Given this list of marker genes RPL29, RPL9, BAMBI, ABHD3, TAF1D, XPO7, SCARB2, OXT, RPL23A, RPS10, GNAS, GNPAT, RPS4Y1, SPTBN1, AHCY, MDK, EPCAM, RPS7, RPL28, HNRNPA1 (heterogeneous nuclear ribonucleoprotein A1), SRPK1, TOMM20, RPS4X, PEG3, RPL13A, RPS3, RPL31, VIL1, RPSA, MPZL2, RPL7A, FMOD, RPS12, PHF20, DSG2, POLR2E, AFP, RPS27A (NCBI Gene Id 6233), TRIM24, CPOX (coproporphyrinogen oxidase), TTK, RPLP0, XK, RPL17, EIF3F, MRPL3, RPS24, RPS3A, RPL6, DKK1, NREP, RPL35 (ribosomal protein L35), PTPN12, here is a description of the gene set: species: Homo sapiens Up-regulated genes distinguishing hepatocellular carcinoma (HCC) samples positive for EPCAM from the negative ones. Human Gene Set: YAMASHITA_LIVER_CANCER_WITH_EPCAM_UP The heterogeneous nature of hepatocellular carcinoma (HCC) and the lack of appropriate biomarkers have hampered patient prognosis and treatment stratification. Recently, we have identified that a hepatic stem cell marker, epithelial cell adhesion molecule (EpCAM), may serve as an early biomarker of HCC because its expression is highly elevated in premalignant hepatic tissues and in a subset of HCC. In this study, we aimed to identify novel HCC subtypes that resemble certain stages of liver lineages by searching for EpCAM-coexpressed genes. A unique signature of EpCAM-positive HCCs was identified by cDNA microarray analysis of 40 HCC cases and validated by oligonucleotide microarray analysis of 238 independent HCC cases, which was further confirmed by immunohistochemical analysis of an additional 101 HCC cases. EpCAM-positive HCC displayed a distinct molecular signature with features of hepatic progenitor cells including the presence of known stem/progenitor markers such as cytokeratin 19, c-Kit, EpCAM, and activated Wnt-beta-catenin signaling, whereas EpCAM-negative HCC displayed genes with features of mature hepatocytes. Moreover, EpCAM-positive and EpCAM-negative HCC could be further subclassified into four groups with prognostic implication by determining the level of alpha-fetoprotein (AFP). These four subtypes displayed distinct gene expression patterns with features resembling certain stages of hepatic lineages. Taken together, we proposed an easy classification system defined by EpCAM and AFP to reveal HCC subtypes similar to hepatic cell maturation lineages, which may enable prognostic stratification and assessment of HCC patients with adjuvant therapy and provide new insights into the potential cellular origin of HCC and its activated molecular pathways. from publication Yamashita T, Forgues M, Wang W, Kim JW, Ye Q, Jia H, Budhu A, Zanetti KA, Chen Y, Qin LX, Tang ZY, Wang XW (PMID 18316609)